Given this list of marker genes EEF1DP3, NDUFA4L2, NRIP2, GUCY1A2, BCAS3-AS1, RGS5, PDGFRB, TAGLN, MAPT, SEMA5B, MYO1B-AS1, ADORA2B, SLC7A11, FOXS1, CARMN (NCBI Gene Id 731803), LINC00702, NKD2, GPR176, COX4I2, RASL12, SULT1E1, EDNRA, KIAA1549L, ENSG00000228033, CACNA1C-IT3, TMEM74B, SLIT3 (slit guidance ligand 3), TRPC4, RBPMS2, NMUR2, CCDC3, ENTPD3, SLC6A1, ANO1, P2RX3, ANKRD20A11P, LINC02237, CCN4, LINGO1, GPC6, MYH11, PLCL1, ABCC9, ITGA11, PAWR (NCBI Gene Id 5074), RERG, CACNA1C, KCNAB1, KCNA5, ACTA2, TMC4, SEPTIN4-AS1, ACTG2, ADRA1D, PDE1B, FHL5, OR51E1, ENPEP, CABP1, ANGPT2, STEAP4, FRK, RAB3B, LEFTY2, RRAD, ADCY5, ACTA2-AS1, WDR72, OR51E2, DAAM2, TEX41, C1QTNF7-AS1, B4GALNT1, PLN, FAM162B, CORIN, AOC3, SLC38A11 (NCBI Gene Id 151258), BMP5, RCAN2, LAMC3, here is a description of the gene set: The gene expression program underlying the specification of human cell types is of fundamental interest. The study authors generated human cell atlases of gene expression and chromatin accessibility in fetal tissues. For gene expression, the study authors applied three-level combinatorial indexing to >110 samples representing 15 organs, ultimately profiling ~4 million single cells. The study authors leveraged the literature and other atlases to identify and annotate hundreds of cell types and subtypes, both within and across tissues. Our analyses focused on organ-specific specializations of broadly distributed cell types (such as blood, endothelial, and epithelial), sites of fetal erythropoiesis (which notably included the adrenal gland), and integration with mouse developmental atlases (such as conserved specification of blood cells). These data represent a rich resource for the exploration of in vivo human gene expression in diverse tissues and cell types. Human Gene Set: DESCARTES_FETAL_MUSCLE_SMOOTH_MUSCLE_CELLS from publication Cao J, O'Day DR, Pliner HA, Kingsley PD, Deng M, Daza RM, Zager MA, Aldinger KA, Blecher-Gonen R, Zhang F, Spielmann M, Palis J, Doherty D, Steemers FJ, Glass IA, Trapnell C, Shendure J (PMID 33184181) Marker genes curated from the annotated cluster as represented in the Descartes Human Gene Expression During Development database. species: Homo sapiens